The following is a description of a gene set: Mouse Gene Set: REACTOME_METABOLISM_OF_NUCLEOTIDES species: Mus musculus Metabolism of nucleotides, and this is the list of marker genes: Entpd4b, Itpa, Ampd1, Nme1, Gart, Guk1, Entpd5 (NCBI Gene Id 12499), Ak5, Ctps1, Impdh2, Adk, Dut, Nt5c1b, Nudt9, Dpyd, Entpd6, Entpd2, Nudt18, Glrx, Nme3, Rrm2, Upp1, Ak4, Ak6, Cda, Aprt, Uckl1, Nme2, Pfas, Ampd3, Cad, Nt5m, Ctps2, Nudt13, Rrm2b (NCBI Gene Id 382985), Txn1, Ppat, Nt5c1a, Gsr, Gda, Xdh, Rrm1, Pnp2, Dck, Tyms, Dhodh, Impdh1, Nt5c3, Pudp, Entpd1, Upb1, Ak8, Cmpk1, Entpd3, Gmpr, Gmpr2, Dtymk, Entpd4, Entpd7, Nudt1, Ak7, Tymp, Ampd2 (NCBI Gene Id 99675), Nt5e, Dpys, Adal, Txnrd1, Dnph1, Dguok (NCBI Gene Id 27369), Upp2, Dctd, Paics, Nudt16, Pnp, Nt5c, Adsl, Ak2, Ada, Uck1, Nudt15, Hprt1, Tk1, Gmps, Umps, Ak1, Entpd8, Ak9, Adprm, Tk2, Uck2 (uridine-cytidine kinase 2), Nudt5, Nt5c2, Nme4, Samhd1, Adss2, Atic, Adss1